The following is a description of a gene set: species: Mus musculus Any process that modulates the rate, frequency or extent of kidney development. Kidney development is the process whose specific outcome is the progression of the kidney over time, from its formation to the mature structure. The kidney is an organ that filters the blood and excretes the end products of body metabolism in the form of urine. Mouse Gene Set: GOBP_REGULATION_OF_KIDNEY_DEVELOPMENT, and this is the list of marker genes: Pax8, Ezh2, Ppp3ca, Tacstd2, Stat1, Agtr2, Hnf1b, Six4, Wt1, Bmp4, Foxd1, Agt, Smo, Sox8, Myc, Lgr4, Hoxb7, Osr1, Ret, Tgfb1, Gata3, Grem1, Lhx1, Nog, Wnt4, Wnt2b, Agtr1a, Vegfa, Sall1, Sox9, Pax2, Maged1, Agtr1b, Ednra, Adipoq, Six2, Bmi1, Gdnf, Six1